The following is a description of a gene set: studied in species Homo sapiens from publication Chen Y, Wang X (PMID 31504780) Human Gene Set: MIR3606_3P Genes predicted to be targets of miRBase v22 microRNA hsa-miR-3606-3p in miRDB v6.0 with MirTarget v4 prediction scores > 80 (high confidence targets)., and this is the list of marker genes: CDK17, WHAMM, CDC73, BMX, TOGARAM1, ZNF34, ETNK1, PPP2R1B, SMARCAD1, DUXA, USP31, CDH19, RNF146 (NCBI Gene Id 81847), CNTN5, SAMD8, PAWR (pro-apoptotic WT1 regulator), TSNAX, CNST, SLC17A6, RPS6KA5, RASSF8, CSGALNACT1, SLC39A12, NAB1, TMCO3, SLC30A6, TBC1D12, MAP3K4, ITCH (itchy E3 ubiquitin protein ligase), SLC7A14, BOLL, ZNF714, SNX15, PHLPP1 (PH domain and leucine rich repeat protein phosphatase 1), CXADR, DENND5B, CCDC141, NUP93, SLC6A4, SREK1, VPS50, EEA1, SPG11, SERPINB8, STXBP5, HTR2C, PABPC4L, CHIC1, YTHDF3, GABRA4, UBE2D3, FAM171B, WDR20, NETO1, LRP6, GOSR2, FSD1L, LYPLA1, CCDC39, DNER, WBP4, LRATD1, ASAP2, ZFAND5, NCBP1, MDFIC, RUFY2, TPMT, SLK, CHCHD7, ZDHHC2, ZFHX4, CREG2, HBS1L, MBNL3, TXNDC16, CARF, RNF138, PIK3CA, TWF1, HIBCH, LANCL3 (NCBI Gene Id 347404), ZBTB41, FBXO33, SP3, ELOC, SLC25A46, DLAT, FAM118B, PPP1R3D, DAZ2, WASF3, SHANK2, ZBTB8A, TRIP12, KDM6A, CNOT6, MTM1 (NCBI Gene Id 4534), MIGA1, FBXO4, ZNF516, SPRED1, PRKACB, TARP, RUNDC3B, GSPT1, LRRC7, NEDD4L, DGKI, RBM27, HPCAL4, TTC28, PDIK1L, UFL1, MSX1, C14orf28, ITGA4, PTPRB, AK2, ZNF320, ZNF287, ADAM10, SH3KBP1, SGPP1 (NCBI Gene Id 81537), HDX, CNOT6L, UMAD1, OLFM3, FST, SNCA, TPRG1, ANGEL2, ADGRG6, ABRAXAS2, EPHA5, PAQR5, ENKUR, UBE2K, KIF13A, CCNE2, MINDY3, NDUFA5, MEIOC (meiosis specific with coiled-coil domain), ZNF148, U2SURP, PEG10, PHIP, MDM4, LCORL, TNPO1, MPPED2, ZNF22, ABRAXAS1 (NCBI Gene Id 84142), LRRC3B, APPL1, RANBP3L, LSAMP, FEM1C, CTDSPL2, PALS2, SLC1A3, EIF4A2, PCDH11X, PTPRC, ANKRD17, TCEANC2, FSBP, CREBZF, FAM20B, PPARG, GPLD1, CALB1, KLHDC1, ENAH, MRC1, NUS1, RBMS3, PPM1E, SLC2A13, PTEN, ALDH6A1, RAD54B, C18orf54, DCUN1D5, LUC7L2, CHD7, ICA1L, LRP8, ASXL2, TOR1AIP2, SYT4, ZFP28, TBX18, NOP2, RCAN3, PHF20L1, LEPROT, TRIM33, ZFYVE16, KCNS3, ERO1B (NCBI Gene Id 56605), PRP4K, YWHAZ, SUV39H2, ABI1, TMTC3, SPRYD7, SAR1A, PRKG1, C5orf24, PPP3CA, HACE1, MACIR, BAMBI, CACNB4, ZNF367, FAM133A, STRN, NEUROG2, TLCD4, RSKR, FAS, GNAI3, FLYWCH1, RNF6, MOB1B, BICC1 (NCBI Gene Id 80114), TCF12, EDEM1, KLF15, BCL11B, RICTOR, ZNF326, PPP2CB, CUL3, GYPA, GPR180, SLC22A5, SLC7A11, RXFP1, SPIRE1, CHST9, SEMA5A, CADM2, RELCH, TSC22D1, UEVLD, IGF2BP3, CNN3, ALCAM, KLRD1, MGST1, TXNDC11, HEXIM1, TRDMT1, MTF2, KCTD1, SLC35F5, CPEB3, PGAP1, LIN9, SLC12A2, PCDH8, NT5DC1, ANGPTL3, SLC26A2, HLTF, C7, TMEM170B, RAB8B, MED13 (NCBI Gene Id 9969), DRD1, CYBRD1, ARFGEF3 (ARFGEF family member 3), RETSAT, AFF4, DAZ4, MXI1, NOTCH2, RFX3, ASB7, GASK1B, GAB1, TOP2B, MATR3, ANTXR2, VPS37A, XRN1, ZNF678, TMEM33, DCAF10, ARG1, PTP4A1, STOX2, RC3H1 (NCBI Gene Id 149041), CSNK1A1, COL6A3, AGFG1, ABHD13, HSPA5, TMEM38B, BCL2L13, NAPEPLD (NCBI Gene Id 222236), ZC2HC1A, PARPBP, LHX8, TMF1, DR1, KCNC2, CCDC186, KDM7A, JPH4, GTF2H5, FEM1B, LIN54, CDK19, FAM114A1, ARMH4, FUT9, ZCCHC9, SEC23A (SEC23 homolog A, COPII coat complex component, NCBI Gene Id 353367), SGIP1, B4GALNT4, PFKFB3, SERINC5, ZNF736, SLFN5, SYPL1, ELK4, TOPORS, LRRC4C, PDE8A, SLC4A7, SMARCA1, SCAI, ARL6IP6, RNF103, FGFR1OP2, RBBP5, ARHGAP29, PKP2, RANBP9, CREB1, HNRNPK, AZIN1, KALRN, NUFIP2, ELF2, IKZF2, ZDHHC21, IL6ST, CSRNP3, FMR1, DTWD2, SH3GLB1, NDUFB8, ADAMTS5, SPOCK3, ELAVL2, RELN, PPP1R9A, ELF1, MAP7